The following is a description of a gene set: An activity that facilitates the formation of a complementary double-stranded RNA molecule. Mouse Gene Set: GOMF_RNA_STRAND_ANNEALING_ACTIVITY species: Mus musculus, and this is the list of marker genes: Fxr1, Eif4b, Fmr1, Ddx3x, Hnrnpa1, Eif4h, D1Pas1